Given this list of marker genes FLII, TMOD3, ARHGEF2, CFL1, ACTN2, CAPZA2, PPP1R10, PLEK, MAP6D1, CAPZB, TBC1D25, ATG12, SETX, AVIL, SPECC1L, EIF5A, SPTBN2, GAS2L2, UPF1, EPS8, INSR, TWF2, EIF5A2 (eukaryotic translation initiation factor 5A2), CKAP2, VILL, DMTN, CLEC16A, SCIN, CAPZA3, LIMA1, TPX2, TRIOBP, CLASP2, TMOD4, WASHC2C, ADD1, STMN2, GSPT1, SPTA1, CAMSAP2, SCAF4, TTBK2, WNK1, ADD3, PLEKHH2, MAP1S, APC2, TNF, KATNB1, MAP1A, TRIM54, OGFOD1, CARMIL2, DSTN, TMOD2, SPTB, GSN, SLN, BBOF1, HDGFL3, FYCO1, TMEM39A, SMCR8, CARMIL1, AURKB, SVIL, UBQLN4, SPAST, SPTAN1, FGF13, BNIP3, RDX, CAPG, SPTBN4, CAPZA1, CRACD, PHF23, PDXP, F2RL1, TAOK1, TOM1, MID1, ADRB2, VIL1, RUBCN, WDR47, GAS2L1, WDR1, ATXN7, APC, SH3BP1, PPP1CA, NAV3, SEMA5A, TECPR1, LMOD3, EIF5AL1, MID1IP1, SPTBN5, TRPV4, UVRAG, ASPH (aspartate beta-hydroxylase), ASB2 (ankyrin repeat and SOCS box containing 2), IRAK3 (interleukin 1 receptor associated kinase 3), CALCOCO2, IRGM, ADD2, ZMPSTE24, BMERB1, SPEF1 (sperm flagellar 1), KIF21A, MAP1B, CLASP1, CIB1, LMOD2, DIAPH3, SCAF8, CFL2, SWAP70, SPTBN1, IGF1R, CLN3, CCDC88C, JMJD4, PIK3CA, TMOD1 (tropomodulin 1), HDAC6, ATG5, ETF1, NES, SHFL, LMOD1 (NCBI Gene Id 25802), MTPN (myotrophin), TWF1, here is a description of the gene set: species: Homo sapiens Any process that modulates the frequency, rate or extent of protein complex disassembly, the disaggregation of a protein complex into its constituent components. Human Gene Set: GOBP_REGULATION_OF_PROTEIN_CONTAINING_COMPLEX_DISASSEMBLY